The following is a description of a gene set: species: Homo sapiens Any process that modulates the rate, frequency or extent of T cell chemotaxis. T cell chemotaxis is the directed movement of a T cell in response to an external stimulus. Human Gene Set: GOBP_REGULATION_OF_T_CELL_CHEMOTAXIS, and this is the list of marker genes: OXSR1 (oxidative stress responsive kinase 1), ADAM17, XCL1, CXCL10, WNT5A, CCL21 (C-C motif chemokine ligand 21), CXCL13, TNFSF14, S100A7, CCR2, ADAM10, CCL5, WNK1, STK39, TMEM102